Given this list of marker genes NF1, FCER1G, STAT5A, ADAM17 (NCBI Gene Id 6868), KITLG, here is a description of the gene set: species: Homo sapiens Any process that modulates the frequency, rate, or extent of mast cell apoptotic process. Human Gene Set: GOBP_REGULATION_OF_MAST_CELL_APOPTOTIC_PROCESS